The following is a description of a gene set: Mouse Gene Set: chr17E4 species: Mus musculus, and this is the list of marker genes: Abcg5, Gm29418, Zfp36l2, Foxn2, Gm24492, Gm26005, Rpl31-ps16, Gm31499, Six3os1, Ppp1r21, Ston1, Gm50012, Atp6v1e2, Gm10309, Kcnk12, Abcg8, Gm5499, 4930500A05Rik, Gm30938, 4833418N02Rik, Gm46587, Srbd1, Plekhh2, Rpl21-ps7, Mcfd2, Epcam (NCBI Gene Id 17075), 2010106C02Rik (RIKEN cDNA 2010106C02 gene), Gm41638, Gm41639, Eml4, Gm35551, Tmem247, 1110020A21Rik, Msh6, Gm9406, Kcng3, Gm30984, Dync2li1, Rhoq, Epas1, Gtf2a1l, Slc3a1, Gm35229, Pigf, 4933433H22Rik, Gm30117, Camkmt, Ppm1b, Thada, Gm19696, Gm18832, Gm24240, Prkce, Prepl, Lrpprc, Gm22542, Gm30794, Lhcgr, Gm36279, Socs5, 8430430B14Rik, Ttc7, Six2, Gm46606, Gm19689, Gm31615, Rpl36-ps4, C330024C12Rik, C430042M11Rik (RIKEN cDNA C430042M11 gene), Gm4832, 1810073O08Rik, 0610012D04Rik, Six3, Gm9400, Gm9407, Cript, Gm5231, Calm2, CJ186046Rik, Gm4601, Pkdcc, Gm24648, Fbxo11, Mta3, Cox7a2l, Msh2, Haao, Stpg4